The following is a description of a gene set: Serial comparison between Th1 and Th17 tumor-specific cells cultured in vitro and ex vivo after transferred into sublethaly irradiated B6.PL mice. Th17-derived cells acquire Th1-like properties in vivo but maintain a distinct molecular profile. studied in species Homo sapiens Human Gene Set: GSE26030_UNSTIM_VS_RESTIM_TH17_DAY5_POST_POLARIZATION_DN Genes down-regulated in Th17 cells 5 days post polarization: control versus stimulated with anti-CD3 and anti-CD28. from publication Muranski P, Borman ZA, Kerkar SP, Klebanoff CA, Ji Y, Sanchez-Perez L, Sukumar M, Reger RN, Yu Z, Kern SJ, Roychoudhuri R, Ferreyra GA, Shen W, Durum SK, Feigenbaum L, Palmer DC, Antony PA, Chan CC, Laurence A, Danner RL, Gattinoni L, Restifo NP (PMID 22177921), and this is the list of marker genes: OR6W1P, SLCO4A1, DIPK2B, LRRC8B, NIBAN2, NUDT16L2P, NDUFC2, ABCG2, PCYT1A, AP2M1, APBB1IP, PITRM1, REEP5, SPINT2, MCUR1, XPO5 (exportin 5), CLIC5, ANKRD18A, SLA, DIP2C, HARBI1 (NCBI Gene Id 283254), CD1C, SLC25A15, OCSTAMP (osteoclast stimulatory transmembrane protein), CFAP251, MPDU1, BCL7A, COL5A3, PHOSPHO1, SDC2, ARF4, PMM2, OR5B3, CDR2, G6PD, CLDN1, SYT17, EBF2, ADAM15 (NCBI Gene Id 8751), IRF4, FCER2, ALOX15, RNF32, TES, WNT5A, ALDH1A2, TXNRD1, MTCL1, TLE1, ATP1A1, AQP9, SLC26A6, P4HA2, CD1B, OR2S2, PPARGC1B, VIM (vimentin, NCBI Gene Id 7431), UBAP2L, PTGER2, ARRDC4, OR5AK3P, FLT1, SLC12A9 (solute carrier family 12 member 9), LYRM1, ORM1, FLVCR2, FAM110B, BCAT2, AMPD2, ATF5, CD83 (NCBI Gene Id 9308), CD226, IRGQ, OR2V2, DDO, SMURF1, AIFM1, ATP6V0A2, OR10AD1, UBE2F, SYNJ2, CD1A, CACNB4, MFN2, RYK, GTF2E2, GALNT18, SLC22A4, GFOD1, ATP5MK, PLCB2, PITPNA, CDKN1A, NIPAL1, WFS1, EHD4, NPC1, SLC9A2, CAPN6 (calpain 6), BLTP2, ANXA11, DHRS11, SEC23B, RPS2P45, SLC25A48, PDGFB, RRAGD, PPFIBP1, FAM86DP, PLXNA2, NUDT16, NDUFA6, MDH1, SLC10A1, LCP1, TNFRSF10A, ERI1, ETS1, NSDHL, MAOA, PARP12, CTNNAL1, FAR2, BATF3, JAG1, CISH, BICD2, CASS4, SOCS1, HSD11B1, PRKY (NCBI Gene Id 5616), NCF2, ACTB (NCBI Gene Id 60), UQCRC1, MYH9, XPNPEP1, PPP1R14A, NDFIP2, TIMP3, PALLD, ACSL5, MFSD14B, PTPRE, CD274, MATK, TCTE1, CD1E, DBNL, JUN, RPIA, DNASE1L3, FKBP1A, PM20D1, SERINC5, RAB35, CD300LB, MMP12, PARM1, CHCHD7, ACAA2, PPARG, AKIRIN2, METTL1, FADS3, AKAP5, DRAP1, RBM11, DNPEP, NIPA2, TRAF1, ATP6V1G1, MESD, FST, TIFA, NOL6, CCL4, MINAR1, HOMER2, CASP7, PDXK, SNX8, SLC27A3, CTNS, PFKP, COA6, TSC22D2, PRPS1, PER2, RAB30 (NCBI Gene Id 27314), AKAP12, SLC50A1, CAVIN1, TBC1D8, BMP6, CES3, HGS (NCBI Gene Id 9146), BCAR3, NOCT